The following is a description of a gene set: species: Mus musculus Any process that results in a change in state or activity of a cell (in terms of movement, secretion, enzyme production, gene expression, etc.) as a result of a follicle-stimulating hormone stimulus. Mouse Gene Set: GOBP_CELLULAR_RESPONSE_TO_FOLLICLE_STIMULATING_HORMONE_STIMULUS, and this is the list of marker genes: Gata4, Ppargc1a, Gata1, Epha8, Epha5, Notch1, Pde4d, Inhba, Gclm, Fshr, Star, Ednra, Efna5, Akr1c18, Edn1, Epha3, Gclc